Given this list of marker genes GALE, here is a description of the gene set: Reactome Pathway: Defective GALE causes EDG part of: Diseases associated with glycosylation precursor biosynthesis Cytosolic UDP-galactose 4'-epimerase (GALE) catalyses the reversible interconversion of UDP-D-galactose (UDP-Gal) and UDP-glucose (UDP-Glc), the third reacton in the Leloir pathway of galactose metabolism. GALE can also catalyse the epimerisation of UDP-N-acetylglucosamine to UDP-N-acetylgalactosamine. The active form of the enzyme is a homodimer with one molecule of bound NAD per monomer (GALE:NAD+ dimer). Defects in GALE can cause Epimerase-deficiency galactosemia (EDG; MIM:230350), or type III galactosemia (diseases of galactose metabolism) whose clinical features include early-onset cataracts, liver damage, deafness and mental retardation. Historically, it was considered that there were two forms of GALE deficidency; a benign ("peripheral") form where there is no GALE activity in red blood cells and characterised by mild symptoms and a rarer "generalised" form with no detectable GALE activity in all tissues resulting in more severe symptoms. The disease is now considered to be a continuum. species: Homo sapiens